Given this list of marker genes SLC13A3, SLC13A4, SLC13A5, SLC13A1, SLC13A2, here is a description of the gene set: Human Gene Set: REACTOME_SODIUM_COUPLED_SULPHATE_DI_AND_TRI_CARBOXYLATE_TRANSPORTERS studied in species Homo sapiens Sodium-coupled sulphate, di- and tri-carboxylate transporters